Given this list of marker genes KAT2A, NEURL1B, NCOR2, HDAC7, JAG2, NEURL1, HDAC4, MAML2, HDAC8, KAT2B, RPS27A, SKP1, HDAC1, ADAM17, MAML1, PSENEN, APH1B, CCNC, APH1A, HDAC2, TBL1XR1, MIB1, UBB, DLL4, NCOR1, CREBBP, HDAC11, UBA52, CUL1 (NCBI Gene Id 8454), RBX1, EP300, HDAC5, DLL1, MAML3, MIB2, HEY2, PSEN1, HDAC10, MAMLD1, NOTCH1, FBXW7, PSEN2, RBPJ, SNW1, HEYL, HES5, TBL1X, HDAC3, HDAC6, HES1 (hes family bHLH transcription factor 1), JAG1 (NCBI Gene Id 3715), HEY1, UBC, ADAM10, HDAC9, CDK8, MYC, NCSTN (NCBI Gene Id 57297), here is a description of the gene set: part of: Signaling by NOTCH1 PEST Domain Mutants in Cancer species: Homo sapiens As NOTCH1 PEST domain is intracellular, NOTCH1 PEST domain mutants are expected to behave as the wild-type NOTCH1 with respect to ligand binding and proteolytic cleavage mediated activation of signaling. However, once the NICD1 fragment of NOTCH1 is released, PEST domain mutations prolong its half-life and transcriptional activity through interference with FBXW7 (FBW7)-mediated ubiquitination and degradation of NICD1. All NOTCH1 PEST domain mutants annotated here (NOTCH1 Q2395*, NOTCH1 Q2440*, NOTCH1 P2474Afs*4 and NOTCH1 P2514Rfs*4) either have a truncated PEST domain or lack the PEST domain completely. Reactome Pathway: Constitutive Signaling by NOTCH1 PEST Domain Mutants